Given this list of marker genes Pde4d, Kpna4, Crispld2, Mfge8, Pcdhga7, Erf, Wdtc1, Fam78a, Rai1, Hyou1, Dhrs11, Cited2, Sema4g, Fscn1 (NCBI Gene Id 14086), Foxp4, Vax1, Ggact, Marchf9, Kdm2a, Cxcr4, Klhl18, Taf3, Heatr3, Dnlz, Cst7, Mad1l1, Prlr, Rnf146, Snph, Dlk1, Ptk2b, Insyn2a, Efna5, Alx4, Pin1, Cntnap1, Slc47a1, Pcdhgb8, Pip4k2b, Tbkbp1, Zfp57, Fbxo46, Begain, Tbx5, Bsn, Mex3b (mex3 RNA binding family member B), Pltp, Deaf1, Ncln, Syt7, Nexmif, Rgs6, Cnpy4, Slc7a1, Cxcl14, Myo18a, Nfix, Mex3a, Itga3, Arnt, Gfap, Ankrd33b, Zc3h7b, Gorasp1, Tmcc3, Tbx6, Larp1, Cacna1c, Ppp1r9b, Clmn, Grem2, Cep120, Mecp2, Nucb1, Cramp1, Atf3, Onecut3, Pax7, Tcta, Setd1b, Pcdhga12, Myl6b, Chst1, Tubb4a, Pcdhga1, Daam2, C1qtnf9, Mink1, Aak1, Irag1, Nkx2-2, Rfx1, Gm867, Xkr5, Nova2, Dpysl5, Sema6a, Mcu, Stat3, Sod3, Grin1, Adissp, Pank1, Pcdhga11, Il13, Pip4k2c, Pcdhga5, Afmid, Pcdhga2, Tkfc, Nav1, Gdf3, Tubb6, Cd164l2, Samd4, Lgi3, Cyb5r3, Pcdhgb7, Midn, Nectin1, Stum, Trafd1, Pcdhga10, Syna, Rimbp2, Pcyt1b, Blm, C1ql2, Peli2, Plekhm2 (NCBI Gene Id 69582), Rubcn, Pcdhga8, Kcnh1, Cfap107, Kcnc4, Cd276, Cox10, Igfbp5, Ddx19a, Smarcd1, Tlnrd1, Gng7, Shb, Ubr5, Epha8, Lmod1, Atp1b2, Psca, Tpcn1, Mrps30, Slc6a1, Otud1, Gas7, Ppp1r16b, Adap1, Calcoco1, Eef1a1, Pcdhgc3, Slc6a8, Bcam, Csrp1, Fmnl1, Bmp6, Parvb, Cmip, Vdr, Ptgfrn, Dync1i1, Otof, Diras1, Fndc10, Nol6, Iqsec2, Gsdmc2, Nudt4, Atp2b4, Fzd8, Slc25a33, Nfic, Raver1, Pcdhga9, Zfp703, Ehd1, Ankfy1, Lpcat3, Antxr1, Slc8a2, Rfng, Cnnm1, Myo1d, Pou2f1, Rgp1, Kif21b, Ubtf, Ttyh1, Scn2b, Thrap3, Msi2, Rc3h1, 2410137M14Rik, Cd300a, Lrrtm1, Zfp362, Tead1, Dnajc8, Ercc6, Nptxr, 4931414P19Rik, Mip, Nav2, Ank1, Slc16a2, Dda1, Poll, Rasl10b, Mapre3, Ap1b1, Hexim1, Dagla, Arhgap33, Rap1gap, Kndc1, Cemip, Trio, Rtn4r, Vat1, Plekhh1, Hectd4, Zmynd11, Atcay, Eddm3b, Arrb1, Zfp36l1, Six3, Dscaml1, Kctd11, Pcdhga3, Pitpnm2 (NCBI Gene Id 19679), Fam53b (NCBI Gene Id 77938), Coq8a, Ppp1r3e, Elavl3, Pex19, Or13e8, Phospho1, Gigyf2, Fgf1, Pou4f1, Dnajb5, Vsnl1, Phb1, Actl6b, Iglon5, Eeig1, here is a description of the gene set: Genes predicted to be targets of miRBase v22 microRNA mmu_miR_6931_5p in miRDB v6.0 with MirTarget v4 prediction scores > 80 (high confidence targets). Mouse Gene Set: MIR_6931_5P from publication Chen Y, Wang X (PMID 31504780) species: Mus musculus